Given this list of marker genes Flt3l, Axl, Rasgrp1, Stat5a, Il15, Zbtb1, Irf1, Il15ra, Gas6, Tox, Il21, Stat5b, here is a description of the gene set: Mouse Gene Set: GOBP_POSITIVE_REGULATION_OF_NATURAL_KILLER_CELL_DIFFERENTIATION species: Mus musculus Any process that activates or increases the frequency, rate or extent of natural killer cell differentiation.